Given this list of marker genes S100A6, FBLN2, SLC6A8, PTGS1, CPE, DNM1, SYNPO, MARCKSL1, TAGLN2, PLAC8, HMGA2, PLXNB2, PRRX2, XPO1, PBX3, IL6ST, CCND1, TGFBI, SELENOF, CD44, SERPINE2, VAMP5, CCN5, DLK1, H2AZ2 (H2A.Z variant histone 2), PLP2, TPM4, RBP1, IFITM3, PROS1, VCAM1, ACTN1, FBN1, NONO, S1PR3, RHOJ, TIMP2, CTSV, THY1, CTTN, TMEM45A, SSR3, TIMP1, APBB2, PNP, SLC29A1, BAG6, NQO1, TINAGL1, here is a description of the gene set: from publication Burton GR, Nagarajan R, Peterson CA, McGehee RE Jr (PMID 15033539) studied in species Mus musculus Human Gene Set: BURTON_ADIPOGENESIS_7 Down-regulated at 48-96 h during differentiation of 3T3-L1 cells (fibroblast) into adipocytes. During cellular differentiation and development, it is recognized that many complex molecular mechanisms as well as precise patterns of differentially expressed genes occur in directing precursor cells toward a given lineage. Using microarray-based technology, we examined gene expression across the course of 3T3-L1 adipocyte differentiation. Total cellular RNA was isolated at times 0, 2, 8, 16, 24, 48, and 96 h following treatment with either standard hormonal inducers of differentiation; insulin, dexamethasone, isobutylmethylxanthine (IDX), or IDX plus trichostatin A (TsA), a histone deacetylase inhibitor and potent adipogenic inhibitor. cRNA was synthesized from cellular RNA and hybridized to high density Affymetrix MG_U74Av2 microarray gene chips containing 12,488 cDNA/Expressed Sequence Tags (ESTs) probe sets. From the IDX-only treated cells, all probe sets that were either unchanged or differentially expressed less than 2-fold throughout differentiation with respect to time 0 preadipocytes were excluded from further analyses. This selection resulted in a net of 1686 transcripts, 859 were increased in expression, and 827 were decreased in expression at least 2-fold across differentiation. To focus in on genes that were more specific to differentiation, the same analysis was performed on IDX plus TsA-treated non-differentiating cells and all probe sets from the IDX-only group that exhibited similar expression profiles in the non-differentiating TsA-treated group were excluded leaving a total of 1016 transcripts that were regulated only under differentiating conditions. Six hundred and thirty-six of these transcripts were elevated at least 2-fold and 380 exhibited a decrease in expression relative to time 0 preadipocytes. This group of genes was further analyzed using hierarchical clustering and self-organizing maps and resulted in the identification of numerous genes not previously known to be regulated during adipocyte differentiation. Many of these genes may well represent novel adipogenic mediators and markers of adipogenesis.